Given this list of marker genes PPL, DIO2, COX6A1, GAS2, PDIA4, DBI, INS, UCP1, RTN1, DKK1, FBP1, TACSTD2, RAB11A, RHD, ITIH3, KCNE5, SPARC, MFN1, FGFBP1, MLLT3, SLC34A1, TNNI1, UGT2B10, TFAP2B, PPA1, FMO1, HTATIP2, HSPA8, KAT2B, TMEM45A, NUDT19, TRO, CRX, ZNF239, ANXA8, LAMTOR2, PNOC, HTRA1, KRT12, AMELX, CASP14, CYB561, KRT77, DUSP11, CGA, ALOX15, WSB2, ALPL, NFATC1, ITIH4, HPGD, CDKN2B, GDNF, ETV1, VAMP8, ERBB3, GATM, SERPING1, SIX1, HS3ST1, VCP, RCN1, LGALS2, TGFBI, TPO, PRPH, SUCLG1, CYB5B, METTL9, WLS, BPGM, IGF2R, CCDC80, RARRES2, LSM14B (LSM family member 14B), CALCR, MPO, ZBTB14, FGG, SERPINA10, CST8, APOBEC1, CA3, SCD (stearoyl-CoA desaturase), CCL21, TBXT, MX1, RANBP10, MUC13, IDH1, KLK6, KRT2, CSF1R, GSTM5, CRYBG1, KRT13, KHDC1L, NEFH, POMC (proopiomelanocortin), TSG101, NDUFA3, GRPEL2, ISG15, SULT1B1, CD5L, AKR1B15, ST3GAL4, ERMP1, IL5, LGALS3, CALML4, CHRNA1, LMO7, IL9, FGF3, LTF, ALOX12B, RGN (regucalcin), CALB2, TSC22D1, PTGR1, ZP3 (NCBI Gene Id 7785), CRISP3, MMP13, PEPD, REN, VTI1B, COTL1, CA8, DIAPH3, NAALAD2, MYBPC3, ELF5, SLC39A4, LDLR, PRDX6, NID1, COL6A3, CYP24A1, CCL13, BPIFB1, TXN, GTF2F1, MAGEL2, SYTL4, FMO3, CRYAA, TAC3, HMGCS1, SLC6A13, PCSK5, IRGM, MT4, AMOTL2, SLC12A3, IL7, SUGT1, IFI27, SLC6A8, LIPC, APCDD1, PTPRJ, PPY, SCT, CDKN1C, RPS11, CCL1, CITED2, HBE1, PAH, SLC34A2, ATG5, VNN2 (NCBI Gene Id 8875), EZH1, PLG, FAM171A1, CPNE6, RPTN, CSF3R, MYOC, LDHC, DSP, FABP1, REEP6, LGALS4, RGS2, SAG, GIPC2, NAV1, AKR1C2, PTH1R, GAL (galanin and GMAP prepropeptide), KRT7, RGS8, ARL5A, CES1, WWC1, CLCA1, SCG2, HERC2, here is a description of the gene set: Abstract of publicaton: CD4/CD8 double-positive (DP) thymocytes express the transcriptional repressor Histone Deacetylase 7 (HDAC7), a class IIa HDAC that is exported from the cell nucleus after T cell receptor (TCR) engagement. Through signal-dependent nuclear export, class IIa HDACs such as HDAC7 mediate signal-dependent changes in gene expression that are important to developmental fate decisions in multiple tissues. We report that HDAC7 is exported from the cell nucleus during positive selection in thymocytes, and regulates genes mediating the coupling between TCR engagement and downstream events that determine cell survival. Thymocytes lacking HDAC7 are inefficiently positively selected due to a severely shortened lifespan and exhibit a truncated repertoire of TCR Jalpha segments. The expression of multiple important mediators and modulators of the response to TCR engagement is altered in HDAC7-deficient thymocytes, resulting in increased tonic MAP kinase activity that contributes to the observed loss of viability. Remarkably, the activity of Protein Kinase D, the kinase that mediates nuclear export of HDAC7 in response to TCR signaling, is also increased in HDAC7-deficient thymocytes, suggesting that HDAC7 nuclear export governs a self-sustaining auto-excitatory loop. These experiments add to the understanding of the life/death decision in thymic T cell development, define a novel function for class IIa HDACs, and point to a novel feed-forward mechanism whereby these molecules regulate their own state and mediate stable developmental transitions. Title of manuscript: Nuclear Export of Histone Deacetylase 7 During Thymic Selection Mediates Immune Self-tolerance. abstract of manuscript: Histone Deacetylase 7 (HDAC7) is a TCR signal-dependent regulator of differentiation that is highly expressed in CD4/CD8 double-positive (DP) thymocytes. Here we examine the effect of blocking TCR-dependent nuclear export of HDAC7 during thymic selection, through expression of a signal-resistant mutant of HDAC7 (HDAC7-delta-P) in thymocytes. We find that HDAC7-delta-P Transgenic thymocytes exhibit a profound block in negative thymic selection, but can still undergo positive selection, resulting in the escape of autoreactive T cells into the periphery. Gene expression profiling reveals a comprehensive suppression of the negative selection-associated gene expression program in DP thymocytes, associated with a defect in the activation of MAP kinase pathways by TCR signals. The consequence of this block in vivo is a lethal autoimmune syndrome involving the exocrine pancreas and other abdominal organs. These experiments establish a novel molecular model of autoimmunity and cast new light on the relationship between thymic selection and immune self-tolerance. Goal of Microarray experiment: We did these experiments to determine how alteration of the function of HDAC7, a site-specific and signal-dependent repressor of transcription, changes gene expression in CD4/CD8 DP thymocytes. Genes up-regulated in double positive thymocyte from OT-2 transgenic mice: control versus HDAC7 deltaP form after injection with agonist peptide. Human Gene Set: GSE26488_CTRL_VS_PEPTIDE_INJECTION_HDAC7_DELTAP_TG_OT2_THYMOCYTE_UP from publication Kasler HG, Young BD, Mottet D, Lim HW, Collins AM, Olson EN, Verdin E (PMID 21398603) studied in species Homo sapiens